The following is a description of a gene set: The process whose specific outcome is the progression of the metanephric glomerular mesangium over time, from its formation to the mature structure. The metanephric glomerular mesangium is the thin membrane connective tissue composed of mesangial cells in the metanephros, which helps to support the capillary loops in a renal glomerulus. Human Gene Set: GOBP_METANEPHRIC_GLOMERULAR_MESANGIUM_DEVELOPMENT species: Homo sapiens, and this is the list of marker genes: WT1, EGR1, PDGFB, CD34, PDGFRB (NCBI Gene Id 5159)